The following is a description of a gene set: species: Homo sapiens The series of events involved in the perception of pain in which a mechanical stimulus is received and converted into a molecular signal. Human Gene Set: GOBP_DETECTION_OF_MECHANICAL_STIMULUS_INVOLVED_IN_SENSORY_PERCEPTION_OF_PAIN, and this is the list of marker genes: ASIC3 (acid sensing ion channel subunit 3), PHF24, FYN, HTR2A, TRPA1, TNF, CXCL12, SCN11A, BACE1, NTRK1, SCN1A, ITGA2, TMEM120A, KCNA1